The following is a description of a gene set: Human Gene Set: HP_INFECTION_FOLLOWING_LIVE_VACCINATION Infection following live vaccination An infection resulting from live attenuated vaccines (LAV), that is, a vaccine prepared from living viruses or bacteria that have been weakened under laboratory conditions. LAV vaccines will replicate in a vaccinated individual and produce an immune response but usually cause mild or no disease. are derived from disease-causing pathogens. species: Homo sapiens, and this is the list of marker genes: IRF1, ISG15, MAP3K14, REL, FCGR3A, CORO1A, CYBB, ZNFX1, IFNAR2, MCTS1, RORC, STAT1, ORAI1, IRF8, IFNG, IFNAR1, IL12B, SPPL2A, STAT2, TCF3, DOCK11, DCLRE1C, TBX21, RFX5, IL12RB1